The following is a description of a gene set: Human Gene Set: GOCC_TRANSCRIPTION_EXPORT_COMPLEX species: Homo sapiens The transcription export (TREX) complex couples transcription elongation by RNA polymerase II to mRNA export. The complex associates with the polymerase and travels with it along the length of the transcribed gene. TREX is composed of the THO transcription elongation complex as well as other proteins that couple THO to mRNA export proteins. The TREX complex is known to be found in a wide range of eukaryotes, including S. cerevisiae and metazoans., and this is the list of marker genes: THOC5, THOC2, NXF1, CHTOP, THOC6, SARNP, ZC3H11A, ALYREF, THOC7, THOC1, THOC3, DDX39B